Given this list of marker genes Elmod1, Marcksl1, Tenm3, Ppie, Flcn, Afp, Rab18, Gpr75, Rhebl1, Nts, Hnrnpa0, Stx5a, Mme, Tor1aip2, Satb1, Or6d12, Abi2, Hecw1, Htr1f, Adamts12, Skida1, Gabra2, Pabir2, Vkorc1l1, Psip1, Abcc9, Pigm, Esrrg (estrogen-related receptor gamma), Mex3c, Inpp4b, Wdr26, Cyfip2, Rarres1, Pitx2, Mapk1, Myef2, Ppcdc, Syncrip, Ak7 (adenylate kinase 7), Nkrf, Oscar, Tet2 (NCBI Gene Id 338520), Prph, Rab40b, Treml2, Ttc9c, Cxxc5, Ppargc1a, Gtf3c3, Zfp592, Efemp1, Sertad2, Fgf13, Mfsd4b2, Tex36, Celf4, Tbl1xr1, Zic3, Luc7l3, Slc4a10, Bmpr2, Chfr, Slc31a2, Galnt2 (NCBI Gene Id 14424), Ifitm10, Bmal2, Rab14, Taf7, Atp6v1b2, Mgat4a, Dcun1d4, Exoc6b, Nin, Toe1, Rpe, Rrn3, Ppip5k2, G3bp1, Fryl, Trmt11, Megf11, Mtcp1, Slc8a1, Ubqln2, Prps1l3, Erich5, Hycc2, Sarnp, Meox2, Lurap1l, Vim, Creb5, Afdn, Etf1, Hectd2, Arid2, Zfp462, Zbtb11, Gm5820 (predicted gene 5820), Ube2d3, Kctd12, Phf20l1, here is a description of the gene set: Genes predicted to be targets of miRBase v22 microRNA mmu_miR_5626_3p in miRDB v6.0 with MirTarget v4 prediction scores > 80 (high confidence targets). from publication Chen Y, Wang X (PMID 31504780) species: Mus musculus Mouse Gene Set: MIR_5626_3P